Given this list of marker genes ALDOA, INVS, MT-CO1, SCNN1G, SLC30A9, GABRA3, SEC61A1, OBSCN, PAX2, TBX19, NR3C2, KCNJ18, SCNN1A, CA12, SLC4A2, SLC2A1, MC2R, SAMD9, CACNA1S, POR (cytochrome p450 oxidoreductase), PBX1, MT-CO3, RYR1, WNK1, STAR, SCNN1B, LPIN1, MRAP, SCN4A (sodium voltage-gated channel alpha subunit 4), TXNRD2, WNK4, HSD3B2, CYP11B2, POLG2, NFKB2, ABCB6, KLHL3, NNT, CYP11A1, NR0B1, CUL3, here is a description of the gene set: Human Gene Set: HP_HYPERKALEMIA Hyperkalemia An abnormally increased potassium concentration in the blood. studied in species Homo sapiens